The following is a description of a gene set: This event has been computationally inferred from an event that has been demonstrated in another species.<p>The inference is based on the homology mapping from PANTHER. Briefly, reactions for which all involved PhysicalEntities (in input, output and catalyst) have a mapped orthologue/paralogue (for complexes at least 75% of components must have a mapping) are inferred to the other species. part of: SWI/SNF chromatin remodelers studied in species Mus musculus Reactome Pathway: Formation of the canonical BAF (cBAF) complex electronically inferred by orthology from the curated human pathway, and this is the list of marker genes: Ss18, Ss18l1, Bcl7a, Smarcc1, Bcl7b, Arid1a, Smarca4, Smarcd1, Dpf1, Smarca2, Smarcb1